Given this list of marker genes SCN8A, RASSF8, CDYL, TBX18, ZYG11B, PRDM1, JCAD, CCDC82, DENND5A, PKIA, EIF2B5, WDR82, NDN, CEP85L, CLASP1, AP1S2, JUN, KDR, PTPN21, PIM2, NEDD1, MAPK7 (NCBI Gene Id 5598), LHFPL6, FIGNL2, HIPK1, HIPK3, NUFIP2, SLC35B4, PAG1, NOG, MTF2 (metal response element binding transcription factor 2), CEP41, ZEB1, KRT80, NPC1, TSC22D2 (NCBI Gene Id 9819), ADIPOR2, TUBB, MARCHF6, YPEL2, THAP2, RUSC2, RASA2, IGF2R, RIMS2, DCUN1D5, PGM2L1, CASR, ANK3, FSTL1, LRP1, BNC2, TAP2, SEC23A, ZNF131, GOLGA1, PPP4R2, SCAMP1, SLC6A11, SNRPB2, ITGA1, SESN3, SLK, THAP1, QKI, ATAD2B, SCRT2, CCNE2, ZBTB38, PITPNM3, TFAP2A, PHF21B, KCND2, NANOS1, PHACTR3, CDH20, NRG1, PTBP3, FNDC3B, IPO7, TLN1, MAP4K3, PTHLH, AFF3, ZKSCAN8 (NCBI Gene Id 7745), BAP1, CCNYL1, LIN7A, BCL11B, UBE2W, GLCCI1, SRI, CSMD3, DGKA, PLPP3, ENO4, CCDC177, RSPRY1, ZFTA, PDS5B, ASAP1, LRRC8A, GARRE1, PLXNC1, NTRK2, DNAJB9 (DnaJ heat shock protein family (Hsp40) member B9), A1CF, HNRNPD, CTDSPL2, HMGB3, DPY19L1, RAP1B, KIF14, ZBTB10, NRBP1, MBNL3, NBR1, PHTF2, CFL2, ELOC, IGSF10, S100PBP, STRADB, RIPK2, CORO1C, MGAT2, DNAJB5 (DnaJ heat shock protein family (Hsp40) member B5), OCLN, TSSK1B, ATP5F1B, PPM1E, FLI1, PI4K2B, SLITRK1, FARP1, PHEX, DGKH, REEP1 (NCBI Gene Id 65055), CDK17, FOXN2, ETS1, CYTH1, ARID4B, LARP1B, PIK3CA, MOSMO, XKR4, INTS8, WNT16, MIB1, CECR2 (CECR2 histone acetyl-lysine reader), PCLAF, GNAQ, DIXDC1 (DIX domain containing 1), ARL5A, PRDM16, PTPRZ1, NUDT4 (NCBI Gene Id 57236), IKZF2, PPP1R9A, FBXO33, SRGAP1, BLCAP, ALDH1A1, HDHD2, HOOK3, DNA2, GOLGA7, ATXN1, BLTP3A, SULF1, CNOT6, DLC1, VEGFA, SIX1, HOOK1, DESI1 (NCBI Gene Id 91610), CLIC4, ADH1B, SBSPON (somatomedin B and thrombospondin type 1 domain containing), NOVA2, APOO, TBL1XR1 (TBL1X/Y related 1), PKD1, GXYLT1, RDX, FLII, ZC3H4, GPR180, PCMTD1, ZNF217, RNF19A, ZBTB20, FAM227A, CDYL2, RTF1 (NCBI Gene Id 23168), KCTD8, NOTCH1, ELK4, PPFIA1, C11orf87, CHN2, FEZ2, TRMT9B, ZNF532, MYZAP (NCBI Gene Id 100820829), ESRRG, CLIP1, SEMA6D, PRKACB, MAP3K1, PTAR1, B3GNT2, TLCD5, MARF1 (meiosis regulator and mRNA stability factor 1), MATR3, ERRFI1, SYDE1, SCAI, GIT2, YWHAG, SERINC1, GSTA4, ZFX, RIC1, GPM6A, CAMSAP2, HS3ST3A1 (NCBI Gene Id 9955), DNAJC3, FAM8A1, RANBP10, ZNF711, PAPOLA, FAT3, NAB1, SLC30A7, JAZF1, COPS8, RGL1, TRHDE, ZSWIM4, MBOAT2, DNMT3B, GTF3C4, FN1, ARHGAP20, PPP2R5E, SLC39A14, MINDY2, ZNF326, CRH, ZMAT3, ZCCHC24, LOX, HS2ST1, NR3C1, JKAMP, SUSD5, INSM2, SLC24A4 (NCBI Gene Id 56796), CSNK1G3, ZFAND6, EGLN1, FAM118B, RDH10, RBSN, TBC1D12, USP25, SESN1, KHDRBS1, ERG, ZC3H6, POLK, PPP2R1B, CLASP2, RECK, BDP1, YWHAB, FIGN, CLVS2, RANBP9, XKR8, RNF2, PTPN14, CERT1, SLC1A2, RPS6KA3, PABIR3, ATL2, MPRIP, ADAMTS3, MEX3D, TOB1, STRN, RAB21, AKAP7, IER5, DENND1B, RAB11FIP2, MCFD2, HECTD2, ARIH1, TIMP2, FSD1L, MED13, BICC1, PCDH19, CEP350, FAM227B, ARL2BP, IMMP2L, TRAPPC8, CRKL, WAPL, ZFPM2, PI4KB, VASH1, FRMD6, MPDZ, USP6NL, UBAC2, DENND5B, KDM7A, ARHGAP6, CNTN1, ZDHHC21, BRWD3, MAP2, TSC22D1, LRP1B, MMD, PPM1B, CNEP1R1, YAP1, WASF3, ZNF224 (NCBI Gene Id 7767), CBX4, RPS6KB1, SLC6A1, PROK2, SLC4A7, NOVA1, ANKRD40, CAB39, AGFG1, MBNL2, RAP2C, NTF3, FHL1, CEP97, EDEM3, SLC14A1, WASF1, B3GLCT (NCBI Gene Id 145173), CNKSR3, DDIT4L, SCD, GJC1, SLC35E2A (solute carrier family 35 member E2A (pseudogene)), OSTM1, TRIM33, SECISBP2L, PRKG1, POGLUT2, NFIA, PPP1R10, RBFOX2, KCNQ3, SGIP1, PPP1R18 (NCBI Gene Id 170954), TRIM23, PPP1R9B, PIKFYVE, KYNU, CHSY1, EPS8, ERICH4, NECTIN4, SLIT2, TMEM164, CHRM2, FRMD4B, SGCE, KLF4, PPM1F, GTPBP10, SMARCD1, GLI3, HDAC9, VAT1L, DTNA, KANK2, ZEB2 (zinc finger E-box binding homeobox 2), JAKMIP2, NR5A2, PPHLN1, MIEF1, TMOD3 (tropomodulin 3), TBCA, B4GAT1, WIPF1, CHRNA6, USP27X (ubiquitin specific peptidase 27 X-linked), DPY19L3, FBXW7, HAPSTR1, TOGARAM1, UBE2R2, SNX16, LBR, PTPN12, RRP15 (NCBI Gene Id 57241), MAP4K5, ATP11C, VLDLR, HYCC2, ELK3, MARCKS, SLC25A36, MYB, MAPRE1, SERPINI1, NCOA2 (NCBI Gene Id 10499), PLCL1, CCNJ, GPATCH8, CKAP4, SPAG9, RTKN2, PUM2, ANKRD44, CPED1, CHRDL1, RBFOX3, FBXO30, CASZ1, SLC35E2B, WWC3, GEM, SLF2, EVI5, OTUD4, FOXG1, TENT4B, TAF12, GATA4, SOX2, TCAIM, FOXF1, HMBOX1, CUX1, SDC2, ELMOD2 (NCBI Gene Id 255520), STK4, TMX4, EXOG, KLF6, GPR158, DCBLD2, MFAP5, HS3ST1, NCS1, DACH1, EXD2, MAP4K4, EIF4E2, ROCK2 (Rho associated coiled-coil containing protein kinase 2), SFXN1, PSIP1, PDIK1L, MSN, CRTAP, AMFR (autocrine motility factor receptor), TBK1, PRTG, DZIP1, HSPA13, SYVN1, GPRASP2, CYTH3, TMEFF2, DUSP1, PSAT1, PMAIP1, SUZ12, ELAVL2 (NCBI Gene Id 1993), VASH2, RO60, TMEM17 (NCBI Gene Id 200728), CNOT9 (NCBI Gene Id 9125), GAS2L3, CBL, GPATCH2L, FSCN1, SEMA3F, OSBPL11, NCK2, RND3, SYNJ1 (synaptojanin 1), SCN5A, MSL2, NPM1, ULK2, TLN2, GABBR2, PICALM, ELL2, DPH6, PLPPR4, NAP1L5, FERMT2, here is a description of the gene set: Human Gene Set: MIR429 Genes predicted to be targets of miRBase v22 microRNA hsa-miR-429 in miRDB v6.0 with MirTarget v4 prediction scores > 80 (high confidence targets). species: Homo sapiens from publication Chen Y, Wang X (PMID 31504780)